Given this list of marker genes Mios, Zeb2, Lgsn, Klf10, Folr2, Parp2 (poly (ADP-ribose) polymerase family, member 2), Wdr45, Src, Rptor, Tspo, Mfsd2a, Rara, Gcgr, Sstr3, Serpinc1, Agl, Txn2, Prl8a2, Prox1, Bcl10 (NCBI Gene Id 99555), Cntnap2, Cubn, Ahcy, Prr5, Mlycd, Lta, Prl7c1, Stk-ps2, Gstp1, Prkab2, Zc3h12a, Mfsd11, Ucp1, Ptgs2, Foxa3, Il1a, Atxn3, Bnip3, Folr1, Ahcyl, Sctr, Mc4r, Cadps2, Fbn1, Ifi213, Col6a1, Ifi209, Tsc2, Prl7b1, Gpr39, Cbs, Wrn, Prl3a1, Gdf3, Ifi206, Bche, Prl2c5, Atn1, Ercc1, Gpt, Chac1, Fabp1, Alpl, Gast, Pter, Kank2, Gpx1, Sgip1, Pak4 (p21 (RAC1) activated kinase 4), Seh1l, F7, Slc16a1, Gcn1, Ucp3, Csnk1a1, Usf2, Upp1, Asl, Igfbp2, Srebf1, Pdk4, Cartpt, Gabarapl1, Foxo1, Stk39, Guca2b, Sirt2, Hspa5, Ambra1, Nprl3, Ptpn1, Ehmt2 (NCBI Gene Id 52041), Nfkbiz, Rps6kb1, Npy, Bmp7, Myh13, Nqo1, Gba1, Cyp27b1, Crebbp, Srebf2, Trp53, Srd5a2, Hfe, Chsy1, Prl6a1, Chka, Stk26, Adipoq, Agtr1b, Plin2, Dap, Elapor1, Cfh, 4933438K21Rik, Hmox2, Pik3c2b, Map1lc3b (NCBI Gene Id 67443), Gprin3, Wdr59, Dnmt3a, Brip1, Tsc1, Fbxo22 (F-box protein 22), Sec13, Lrrk2, Wnk4, Rela, Gdap1, Scap, Mybbp1a, Hcrt, Acacb, Ywhaz, Ascl1, Atf4, Mkks, Prkcg, Rnase4, Mt3 (NCBI Gene Id 17751), Kcnb1, Nppb, Chrna7, Inhbb, Psph, Ghr, Lpl, Gatm, Eif2ak4 (NCBI Gene Id 27103), Insr, Dele1, Egfr, Sesn1, Prl3d1, Pld1, Tnf, Otc, Slc22a3, Map1b, Ace, Slc34a1, Ghrh, Ifi203-ps, Gip, Ppara, Tpcn2, Sirt6, Fnip1, Lars1, Prl8a8, Xpr1, Gpr180, Sod1, Eif2a, Ifi203, Mapk14, Foxk1 (forkhead box K1), Pparg, Tbc1d7, Sox2, Th, Tbc1d5, Enpp1, Depdc5 (DEP domain containing 5), Zeb1, Kl, Tnrc6a, Gsta1, Slc39a4, Pak1, Hlcs, Prkag1, Dram1, Dsc2 (NCBI Gene Id 13506), Acsl1, Eif2ak2, Spx, Rxrb, Sstr2, Ppm1d, Slc38a3, Mapk8, Comt, Lrp11, Stc1, Ywhag, Kat2b, Acbd7, Tbxa2r, Bmp8b, Prl2c1, Eif2ak1, Rictor, Mbd2, Pdk2, Acadm, Vdr, Mtor, Rmi1 (NCBI Gene Id 97878), Ogt, Ccl2, Gm14151, Wdr45b, Ogg1, Nod2, Ucn3, Prl8a6, Cdkn2d, Jmy, Htr2c, Eif4g1 (NCBI Gene Id 320196), Gm15441, Atg14, Bglap2, Sar1a, Med1, A2m (alpha-2-macroglobulin), Fos, mt-Cytb (mitochondrially encoded cytochrome b), Prl8a1, Eif2b1, G6pc1, Galp, Scnn1b, Phex, Prss2, Mapt, Fes, Tfam, Blvra, Nprl2, 4921509C19Rik, Pdx1, Sfrp1, Nr1h4, Acvr1c, Cbl, Spp1, Adrb2, Ntrk1, Trpa1, Dnajc15, Fcor (Foxo1 corepressor), Mbd3, Cnr1, Gh, Oprm1, Mettl14, Wdr24, Slc6a4, Ldlr, Penk, Lipg, Cyp26b1, Tnc, Sesn3, Bhlha15, Ctsk, Adm, Ulk3, Hrk, Wnt4, Mdm2, Lct, Sh3glb1, Hsd11b2, Cyp1b1, Rragd, Gm15222, Ulk2, Abcc8, Apoe, Kics2, Gdf15, Tnfrsf11a, Atg5, Prkag3, Gcg, Tmem135, Tyms (thymidylate synthase), Srf, Prl3d2, Pak2, Fam107a, Scd4, Abcg5, Apaf1, Tnks, Sp7 (NCBI Gene Id 319961), Prkcb, Clic5, Prl2a1, C1qtnf4, Gas6, Gfral, Sorl1, Suv39h1, Ucn2 (NCBI Gene Id 171530), Aacs, Usf1, Arsa, Yars1, Mfsd5, Sod2, Bax, Cd68, Pitx2, Becn1, Atf2, Htr4 (5 hydroxytryptamine (serotonin) receptor 4), Pyy, Asns, Pck2 (NCBI Gene Id 74551), Gnpat, Sct, Ifi214, Wipi1, Meak7, Cpeb4, Pck1, Lamp2, Atg4b, Max, Adipor2 (adiponectin receptor 2), Castor1, Pfkfb1, Zfyve1, Trim24, Pmaip1, Slc25a25, Appl2, Acvr2a, Nucb2, Mapk3, Cdkn2b, Gria1, Abca1, Wipi2, Vps41, Ttc5, Pcsk9, Epo, Nupr2, Prl3d3, Ifi208, Glul, Cybb, Slc38a2, Fasn, Ppargc1a, Prl2b1, Nfe2l2, Xbp1, Aldh1a2, Pdia3, Srsf2, Rraga, Micu1 (mitochondrial calcium uptake 1), Abcg8, Nppc, Mlst8, Inhba, Itga2, Arsb, Rasal2, Prl5a1, Oma1, Prlh, Tnfrsf11b, Pnpla3, Bglap, Rbp1, Prl2c2, Gstt1, Kdm4a, Acat1, Jun, Prl8a9, Gpr82, Star, Pak6, Slc10a1, Cd3e, Kynu, Serpina7, Eif4ebp1, Prl3c1, Nenf, Becn2, Gpr155, Pcsk1n, Slc6a19, Tbl2, Scd1, Bcl2, Gclm, Bbs2, Prkaa2, Col1a1, Eif2ak3, Mlxipl, Ugt1a1, Or4m1 (NCBI Gene Id 258658), Gas2l1, Gck, Tmigd1, Mup1, Cyp1a1, Acaa1a, Oxt, Bcas3, Bmf, Tmem126b, Pick1, Nmur2 (neuromedin U receptor 2), Mn1, Lipa, Krt20, Bbs4, Smdt1, Ifi207, Sesn2, Akt1, Map1lc3a, Ass1, Prkd1, Sar1b, Plin3, Myod1, Tgfb1, Tbl1xr1, Mtmr3, Hspa8, Ralb, Slco2b1, Otud3, Mndal, Ripor1, Map3k5, Wnt11, Stc2 (stanniocalcin 2), Clec16a, Cckar, Tfrc, Slc2a1, Trpv1, Wnt9b, Dpyd, Ghrl, Slc2a2, Tcf7l2, Prkaa1, Alb (albumin), Zfp36 (zinc finger protein 36), Rnf167, Ada (adenosine deaminase), F5, Prkab1, Reg1, Ep300, Pak3, Trim25, Suox, Tfeb, Sstr1, Atg7, Etnppl, Stk24, Ncoa1, Casr, Eif2s1, Prl, Ghsr, Rnf152, Pemt, Capn10, Ppard, Slc39a5, Ulk1, Gabarap, Cck, Prl3b1, Fbp1, Foxo3, Sik2, Mapkap1, Mapk1, Bmt2, Gabarapl2, Npff, Fads1, Lrat, Pex2, Cdkn1a, Ctsl, Foxk2, Cntn2, Pik3r4, Cad, Higd1a, Pak5, Ucn, Pcsk1, Mpo, Lep, Larp1, Snai2, Alad, Flcn, Sirt1, Kptn, Rxra, Lrp6, C2, Cyp24a1, Postn, Usp33, Wnt2b, Pik3c3, Ddit3 (NCBI Gene Id 13198), Mafb, Rheb, Mat2a, Rrp8, Prmt1, Adrb3, Foxo4, Kat2a, Bglap3, Fas, Bckdhb, Pik3c2a, Prl7a1, Tyr, Itfg2, Hmgcs2, Bmpr2, Sfrp2, Ucp2, Pomc, Snw1, Lamtor1, Mcu, Yme1l1 (NCBI Gene Id 27377), Rragb, Adrb1, Gad2, Nuak2, Prl7a2, Szt2, Adcyap1, Kcnj11, Prl4a1, Adsl, Fgf23 (NCBI Gene Id 64654), Fkbp1b, Impact, Clps, Cat, Prkag2, Prkch, Cpt1a, Plec, Trim32, Atf3, Trpv4, Cps1, Mlx, Clpsl2, Vgf, Slc7a5, Gsta4, Kat5, Prl2c3, Kdm6a, Pim1, Slc27a4, Rragc, Prl7d1, Angptl4, Maf (MAF bZIP transcription factor), Abcb1a, Gclc, here is a description of the gene set: species: Mus musculus Any process that results in a change in state or activity of a cell or an organism (in terms of movement, secretion, enzyme production, gene expression, etc.) as a result of a stimulus reflecting the presence, absence, or concentration of nutrients. Mouse Gene Set: GOBP_RESPONSE_TO_NUTRIENT_LEVELS